The following is a description of a gene set: Human Gene Set: GOBP_NEGATIVE_REGULATION_OF_CD8_POSITIVE_ALPHA_BETA_T_CELL_ACTIVATION Any process that stops, prevents or reduces the frequency, rate or extent of CD8-positive, alpha-beta T cell activation. species: Homo sapiens, and this is the list of marker genes: ZBTB7B, LILRB1, SOCS1, DAPL1, CD274, SLC4A2, VSIR, HFE